The following is a description of a gene set: studied in species Homo sapiens Binding to collagen, a group of fibrous proteins of very high tensile strength that form the main component of connective tissue in animals. Collagen is highly enriched in glycine (some regions are 33% glycine) and proline, occurring predominantly as 3-hydroxyproline (about 20%). Human Gene Set: GOMF_COLLAGEN_BINDING, and this is the list of marker genes: SMAD4 (SMAD family member 4), ITGA3 (integrin subunit alpha 3), RELL2, CCBE1, ITGA2, SERPINH1, COMP, ADGRG1, THBS1, HSPG2, PODN, MMP13, PDGFA, P3H4, TMEM131, GP6, ACHE, ANTXR1, COCH, PDGFB, SMAD3, CRTAP, SPOCK2, DDR2, FN1, MMP9, SPARCL1, CHADL, LACRT, P3H1, PCOLCE2, CTSS, LOX (NCBI Gene Id 4015), NID2, COL14A1, DSPP, SPARC, NID1, CTSK, ITGA1, SMAD7 (SMAD family member 7), VTN, HSD17B12, ITGA10, MRC2, TGFBI, ADAM9, ADGRG6 (NCBI Gene Id 57211), SPOCK1, ITGB1, USH2A, PAK1, ECM2, VWF, CTSB (NCBI Gene Id 3896), LRRC15, CTSL, DDR1, TNXB, PCOLCE, COL6A2, COL5A3, SPOCK3, C1QTNF1, PPIB, LUM, CD44, ITGA11, AP1G1, MMP12, AEBP1, COL6A1